The following is a description of a gene set: part of: CaM pathway One important physiological role for Calmodulin is the regulation of adenylylcyclases. Four of the nine known adenylylcyclases are calcium sensitive, in particular type 8 (AC8). studied in species Homo sapiens Reactome Pathway: Calmodulin induced events, and this is the list of marker genes: ADCY5, CAMK4 (NCBI Gene Id 814), PRKAR2B, PRKX, CAMK2G, PRKAR1B, PRKACB, CREB1, ADCY1, CAMKK2, ADCY8, CAMK2B, CALM1, ADCY7, KPNA2, ADCY9, ADCY6, ADCY3, ADCY4, PDE1C, PRKACA, PRKCD (NCBI Gene Id 5580), GRK2, NBEA, PDE1A, CAMK2A, PRKCA, PDE1B, PRKACG, PRKAR2A, ADCY2, CAMK2D, PRKCG, CAMKK1, PRKAR1A